The following is a description of a gene set: Human Gene Set: ZHANG_RESPONSE_TO_CANTHARIDIN_DN studied in species Homo sapiens Cantharidin is a natural toxin that has antitumor properties and causes leukocytosis as well as increasing sensitivity of tumor cells resistant to other chemotherapeutic agents. There is limited information, however, on the molecular pharmacological mechanisms of cantharidin on human cancer cells. We have used cDNA microarrays to identify gene expression changes in HL-60 promyeloid leukemia cells exposed to cantharidin. Cantharidin-treated cells not only decreased expression of genes coding for proteins involved in DNA replication (e.g., DNA polymerase delta), DNA repair (e.g., FANCG, ERCC), energy metabolism (e.g., isocitrate dehydrogenase alpha, ADP/ATP translocase), but also decreased expression of genes coding for proteins that have oncogenic activity (e.g., c-myc, GTPase) or show tumor-specific expression (e.g., phosphatidylinositol 3-kinase). In contrast, these treated cells overexpressed several genes that encode intracellular and secreted growth-inhibitory proteins (e.g., BTG2, MCP-3) as well as proapoptotic genes (e.g., ATL-derived PMA-responsive peptide). Our findings suggest that alterations in specific genes functionally related to cell proliferation or apoptosis may be responsible for cantharidin-mediated cytotoxicity. We also found that exposure of HL-60 cells to cantharidin resulted in the decreased expression of multidrug resistance-associated protein genes (e.g., ABCA3, MOAT-B), suggesting that cantharidin may be used as an oncotherapy sensitizer, and the increased expression of genes in modulating cytokine production and inflammatory response (e.g., NFIL-3, N-formylpeptide receptor), which may partly explain the stimulating effects on leukocytosis. Our data provide new insight into the molecular mechanisms of cantharidin. Genes down-regulated in HL-60 cells (promyeloid leukemia) by cantharidin. from publication Zhang JP, Ying K, Xiao ZY, Zhou B, Huang QS, Wu HM, Yin M, Xie Y, Mao YM, Rui YC (PMID 14639605), and this is the list of marker genes: RPL4, RPSA, IDH3A, EML2, HARS2, PRIM1, ABCC4, TIMM23, RPL15, POLR2H, QDPR, RRM2, POLD2 (NCBI Gene Id 5425), PIK3CA, TUBB7P, SLC27A2, EEF1D, SNRPC, MRPL3, SUPT16H, GTF2H4, MTHFD1, ATP5MC2, TRAP1, HNRNPC, ZNRD2, SNRPA, NOP56 (NCBI Gene Id 10528), ZFYVE26, ZNF200, COX4I1, HADHA, UQCRH, PFKL, RHOC, MYB, SNRPA1, EIF3B, ATP5MC3, SNRPD1, RPS14, RFC5, NDUFB6, NDUFB2, PA2G4, MYC, PGAM1, CTPS1, CDK4, RUVBL2, TIMM17B, TKT, FARSA, NOP16, TUBG1, FARSB, MCM7, NDUFS3, ABCA3, ERCC2, FANCG, RPL29, FABP5, GTF3A, RRM1, SLK, SLC25A6